Given this list of marker genes Tax1bp1, Stk39, Smpx, Slc7a8, Ifitm2, Muc13 (NCBI Gene Id 17063), Tpsab1, Ucp2, Nsf, Asns, Hs3st1, Ero1a, Dhrs3, Pcyt1a, Il7r, here is a description of the gene set: Cytokines mediate cell-cell communication in the immune system and represent important therapeutic targets. A myriad of studies have highlighted their central role in immune function, yet we lack a global view of the cellular responses of each immune cell type to each cytokine. To address this gap, the authors created the Immune Dictionary, a compendium of single-cell transcriptomic profiles of more than 17 immune cell types in response to each of 86 cytokines (>1,400 cytokine-cell type combinations) in mouse lymph nodes in vivo. A cytokine-centric view of the dictionary revealed that most cytokines induce highly cell-type-specific responses. For example, the inflammatory cytokine interleukin-1β induces distinct gene programmes in almost every cell type. A cell-type-centric view of the dictionary identified more than 66 cytokine-driven cellular polarization states across immune cell types, including previously uncharacterized states such as an interleukin-18-induced polyfunctional natural killer cell state. from publication Cui A, Huang T, Li S, Ma A, Pérez JL, Sander C, Keskin DB, Wu CJ, Fraenkel E, Hacohen N (PMID 38057668) Genes positively differentially expressed in cell type: Mast cell upon treatment with cytokine: IL-1α in mouse lymph nodes in vivo. Mouse Gene Set: CUI_MAST_CELL_IL1A_RESPONSE_UP species: Mus musculus